The following is a description of a gene set: This event has been computationally inferred from an event that has been demonstrated in another species.<p>The inference is based on the homology mapping from PANTHER. Briefly, reactions for which all involved PhysicalEntities (in input, output and catalyst) have a mapped orthologue/paralogue (for complexes at least 75% of components must have a mapping) are inferred to the other species. electronically inferred by orthology from the curated human pathway Reactome Pathway: Synthesis of pyrophosphates in the cytosol part of: Inositol phosphate metabolism studied in species Mus musculus, and this is the list of marker genes: Nudt4, Ppip5k1 (NCBI Gene Id 327655), Itpk1, Ippk, Ip6k3, Ppip5k2, Nudt10, Nudt11